Given this list of marker genes CPLX3, UCN, SYNJ1, PRRT2, CLCN3, PRNP, PRKCG (protein kinase C gamma), OPRK1, TULP1, NTRK2, ATCAY, PENK, FMR1, CRHBP, NOS1, GOT1 (NCBI Gene Id 2805), CHRM1, SLC8A2, CALM2, CAD, DLG4, AP1S1, HCN1, SNCA, OPRD1, KCNA2, CPLX1, SYP, VTI1A, SNCB, UNC13C, NTSR1, ITGA2, BSN, CABP4, SYT1, FLRT3, VAMP2, BTBD8, TBC1D24, KCNQ5, CDH8, KCNC1, GIT1, SLC18A2, ADORA1 (adenosine A1 receptor), OPHN1, LRRK2, SLC4A10, GRIK2, ACTG1, SLC18A3, NPY, ADRA2A, DRD2, BAIAP2, SLC1A2, SCRG1, GPER1, CALB1, ATP6V0D1, NPFF, PRSS12, GCH1, KCNC4, PDYN, ELFN1, BIN1, TNN, SLC6A3, MICAL1, RAB3A, CPLX4, OXT, PRKN, FLRT1, SLC18A1, SCGN, CPLX2, PTPN9, SLC4A8 (solute carrier family 4 member 8), GNRH1, SLC8A1, AP3D1, ELK1, UNC13A, GHRH, PACSIN1, CALM1, MME, TSPOAP1, SCN9A (NCBI Gene Id 93955), NTS, ACTB, PNOC, AAK1, SNCG, USH2A, GRIK3, MACO1, CRHR2, KCNC2, UCHL1, GAD1, PRKCB, DMD, KCNC3, SLC32A1, EPHA4, KCNK2, KCNA1, ROR1, UCN3, SLC8A3 (solute carrier family 8 member A3), TPRG1L, KCNA6, RAB5A, PTPRN, SLC1A1, SLC17A8, NMU, CNGB1, GRIN1, CALM3, TANC1, SRSF10, CASR, TPBG, CALB2, UNC13B, SEPTIN6, here is a description of the gene set: Human Gene Set: GOCC_NEURON_PROJECTION_TERMINUS The specialized, terminal region of a neuron projection such as an axon or a dendrite. species: Homo sapiens